Given this list of marker genes PEAK1 (NCBI Gene Id 79834), MARCKS, SIM1, DNER, GOPC, IREB2, NDC1, DNM1, DTX4, AP4M1, FDXACB1, LDAF1, DOCK9, PRDM10, ZNF131, ATF7IP, PMS1 (PMS1 homolog 1, mismatch repair system component), HECA, SLC7A1, FAIM, NDST1, DNAJC24 (DnaJ heat shock protein family (Hsp40) member C24), USP49, SMARCA2, CEACAM6, SLC6A13, PCDH8 (NCBI Gene Id 5100), ITFG2, FGF9, BSN, KIAA0232, ZNF772, ZC3H7B (NCBI Gene Id 80080), GPATCH2L, SLC1A4, GPR158, LILRA2, NAALAD2, CAND1, SERINC5 (NCBI Gene Id 256987), MAP3K20, AFF4, CFAP210, WDFY1, IFT57, DCUN1D1, PTGDR, SDC4, CCNT2, RAP2A, STK17B, RAB1A, CBL, TMEM254, SOBP, ZC3H6, RASGEF1B, ANKHD1-EIF4EBP3, PPP1R3B, ADAM10, ADCY9, OLIG3, NGRN, SNX25, CDC42EP3, GIT1, BACE1, USP6, CCDC191, TRIM33, DENND6A, ACSS1, ZNF584, RICTOR, CCNJ, PDE6B, TAB2, HSDL2, HIPK3, MVB12B, NOVA1, PCDH17, IQCJ-SCHIP1, RRAS2, HPCAL1, YWHAG, CXCL8, SMCR8, PLPP3, PLEKHG3, SGIP1, ASIC1, HOXB5, ATXN7L3B, VPS13A, IDS, TRAK1, BAHD1 (bromo adjacent homology domain containing 1), SLAIN2, DDX39B, ATP6AP2, UBQLN2, ITK, VANGL2, MBTPS2, CTCFL, ETNK1, EIF4EBP3, POU2F1, GPX8, KMT5B, NONO, NFYA, ZNF20, SPRED2, ANAPC1, PRMT2, UBAP2L (ubiquitin associated protein 2 like), CTNNA3, OTULINL, RBFOX2, CEP85, ADGRE2, CCDC198, FANCF (NCBI Gene Id 2188), IQCJ, ELOA, FBXO33, CXCL11, MRPL15, SIRT1, SMIM13, ARHGAP17, TTYH3, CASD1, RNF130, STAG2, SCHIP1, UNC5C, RAB8B, ZNF594, CHL1, ACVR2B, LHFPL2, CAPRIN1, here is a description of the gene set: studied in species Homo sapiens Genes predicted to be targets of miRBase v22 microRNA hsa-miR-140-3p in miRDB v6.0 with MirTarget v4 prediction scores > 80 (high confidence targets). Human Gene Set: MIR140_3P from publication Chen Y, Wang X (PMID 31504780)